Given this list of marker genes Prpf39, Snrpa, Snrpert, Snrpd2, Luc7l3, Luc7l, Snrpc, Snrpb, Snrpd3, Prpf40a, Snrpg, Snrpd1, Snrpf, Snrpb2, Luc7l2, Snrpn, Prpf40b, Snrnp70, Snrpe, here is a description of the gene set: species: Mus musculus Mouse Gene Set: GOCC_U1_SNRNP A ribonucleoprotein complex that contains small nuclear RNA U1, a heptameric ring of Sm proteins, as well as several proteins that are unique to the U1 snRNP, most of which remain associated with the U1 snRNA both while the U1 snRNP is free or assembled into a series of spliceosomal complexes.